The following is a description of a gene set: from publication Li S, Rouphael N, Duraisingham S, Romero-Steiner S, Presnell S, Davis C, Schmidt DS, Johnson SE, Milton A, Rajam G, Kasturi S, Carlone GM, Quinn C, Chaussabel D, Palucka AK, Mulligan MJ, Ahmed R, Stephens DS, Nakaya HI, Pulendran B (PMID 24336226) Many vaccines induce protective immunity via antibodies. Systems biology approaches have been used to determine signatures that can be used to predict vaccine-induced immunity in humans, but whether there is a 'universal signature' that can be used to predict antibody responses to any vaccine is unknown. Here we did systems analyses of immune responses to the polysaccharide and conjugate vaccines against meningococcus in healthy adults, in the broader context of published studies of vaccines against yellow fever virus and influenza virus. To achieve this, we did a large-scale network integration of publicly available human blood transcriptomes and systems-scale databases in specific biological contexts and deduced a set of transcription modules in blood. Those modules revealed distinct transcriptional signatures of antibody responses to different classes of vaccines, which provided key insights into primary viral, protein recall and anti-polysaccharide responses. Our results elucidate the early transcriptional programs that orchestrate vaccine immunity in humans and demonstrate the power of integrative network modeling. species: Homo sapiens Human Gene Set: LI_PBMC_MENACTRA_AGE_18_45YO_ANTI_POLYSACCHARIDE_ANTIBODY_CORRELATION_PROFILE_3DY_DN Genes down-regulated in peripheral blood mononuclear cell 3d vs 0d in adults (18-45) (anti-polysaccharide antibody-correlation profile) after exposure to Menactra, time point 3D, and this is the list of marker genes: IFNA7, ITGB4, IL1A, TNR (tenascin R), C7, MMP12, CFH, CFB, IFNA8, IMPG2, PRL, STAB1, IFNA21, A2M, IFNA10, AMER2